Given this list of marker genes CAPRIN1, BECN1, UBAP2L (ubiquitin associated protein 2 like), HSF1, ATG5, here is a description of the gene set: Any process that starts or increases the rate, frequency or extent of stress-granule assembly, the aggregation, arrangement and bonding together of proteins and RNA molecules to form a stress granule. studied in species Homo sapiens Human Gene Set: GOBP_POSITIVE_REGULATION_OF_STRESS_GRANULE_ASSEMBLY